The following is a description of a gene set: Mouse Gene Set: GOBP_PROTEIN_CATABOLIC_PROCESS_IN_THE_VACUOLE studied in species Mus musculus The chemical reactions and pathways resulting in the breakdown of a protein in the vacuole, usually by the action of vacuolar proteases., and this is the list of marker genes: Vps13a, Mfsd8, Lamp2, Ldlr, Marchf2, Mgat3, Dpp7, Lrp1, Cln3, Tmem106b, Usp8, Ccdc115, Tcirg1, Atp13a2, Psap (prosaposin), Cd81, Slc17a9, Laptm4b, Ap5z1, Grn, Tmem199, Tpp1, Vps35